The following is a description of a gene set: species: Mus musculus Catalysis of the removal of the 4-phosphate group of a phosphatidylinositol phosphate. Mouse Gene Set: GOMF_PHOSPHATIDYLINOSITOL_PHOSPHATE_4_PHOSPHATASE_ACTIVITY, and this is the list of marker genes: Inpp4b, Inpp4a, Synj1, Pip4p2, Pip4p1, Fig4, Inpp5f, Sacm1l